The following is a description of a gene set: Human Gene Set: HP_KERATAN_SULFATE_EXCRETION_IN_URINE species: Homo sapiens Keratan sulfate excretion in urine An increased concentration of keratan sulfate in the urine., and this is the list of marker genes: COL2A1, GNPTAB, GLB1, NGLY1, GALNS